The following is a description of a gene set: Mouse Gene Set: GOBP_POSITIVE_REGULATION_OF_MYOBLAST_DIFFERENTIATION species: Mus musculus Any process that activates or increases the frequency, rate or extent of myoblast differentiation. A myoblast is a mononucleate cell type that, by fusion with other myoblasts, gives rise to the myotubes that eventually develop into skeletal muscle fibers., and this is the list of marker genes: Actl6b, Rbm24, Mef2c, Smarce1, Dubr, Cxcl9, Phf10, Ranbp3l, Ccl8, Mustn1, Myf6, Dpf3, Nr2c2, Smarca2, Xkr8, Arid2, Tnfsf14, Ilk (integrin linked kinase), Akirin1, Cdon, Zfhx3, Actb, Smarcd1, Actl6a, Mapk14, Myog, Neu2, Smarcc1, Smarcd3, Lrrc8a, Csrp3, Arid1a, Boc, Sox4, Btg1, Myod1 (myogenic differentiation 1), Smyd1, Kat5, Igfbp3, Pik3r1, Smarcb1, Plcb1, Flt3l, Smarca4, Brd7, Pbrm1, Smarcd2, Ripor2 (RHO family interacting cell polarization regulator 2), Myf5, Smarcc2, Map3k5, Hif1an